Given this list of marker genes Pcsk5, Ngf (nerve growth factor), here is a description of the gene set: This event has been computationally inferred from an event that has been demonstrated in another species.<p>The inference is based on the homology mapping from PANTHER. Briefly, reactions for which all involved PhysicalEntities (in input, output and catalyst) have a mapped orthologue/paralogue (for complexes at least 75% of components must have a mapping) are inferred to the other species. Reactome Pathway: NGF processing electronically inferred by orthology from the curated human pathway studied in species Mus musculus part of: Expression and Processing of Neurotrophins